Given this list of marker genes Timp2, Mmp2, Cxcl13 (NCBI Gene Id 70783), Vegfd, Fgf2, Csf3, Cxcl5, here is a description of the gene set: Mouse Gene Set: JU_AGING_TERC_TARGETS_UP species: Mus musculus from publication Ju Z, Jiang H, Jaworski M, Rathinam C, Gompf A, Klein C, Trumpp A, Rudolph KL (PMID 17486088) Cell-intrinsic checkpoints limit the proliferative capacity of primary cells in response to telomere dysfunction. It is not known, however, whether telomere dysfunction contributes to cell-extrinsic alterations that impair stem cell function and organ homeostasis. Here we show that telomere dysfunction provokes defects of the hematopoietic environment that impair B lymphopoiesis but increase myeloid proliferation in aging telomerase knockout (Terc(-/-)) mice. Moreover, the dysfunctional environment limited the engraftment of transplanted wild-type hematopoietic stem cells (HSCs). Dysfunction of the hematopoietic environment was age dependent and correlated with progressive telomere shortening in bone marrow stromal cells. Telomere dysfunction impaired mesenchymal progenitor cell function, reduced the capacity of bone marrow stromal cells to maintain functional HSCs, and increased the expression of various cytokines, including granulocyte colony-stimulating factor (G-CSF), in the plasma of aging mice. Administration of G-CSF to wild-type mice mimicked some of the defects seen in aging Terc(-/-) mice, including impairment of B lymphopoiesis and HSC engraftment. Conversely, inhibition of G-CSF improved HSC engraftment in aged Terc(-/-) mice. Taken together, these results show that telomere dysfunction induces alterations of the environment that can have implications for organismal aging and cell transplantation therapies. Cytokines, growth factors, and secreted proteins that show increased expression on a protein array of samples from aged TERC knockout mice.